Given this list of marker genes TMPRSS2, ACE2, M, S, E, N, 7a, SARS coronavirus, complete genome, 3a, VCP, CTSL, here is a description of the gene set: studied in species Homo sapiens Coronavirus replication is initiated by the binding of S protein to the cell surface receptor(s). The S protein is composed of two functional domains, S1 (bulb) which mediates receptor binding and S2 (stalk) which mediates membrane fusion. Specific interaction between S1 and the cognate receptor triggers a drastic conformational change in S2, leading to fusion between the virus envelope and the cellular membrane and release of the viral nucleocapsid into the host cell cytosol. Receptor binding is the major determinant of the host range and tissue tropism for a coronavirus. Some human coronaviruses (HCoVs ) have adopted cell surface enzymes as receptors, angiotensin converting enzyme 2 (ACE2) for SARS-CoV-1 and HCoV NL63. The receptor-bound S protein is activated by cleavage into S1 and S2, mediated by one of two of two host proteases, the endosomal cysteine protease cathepsin L and another trypsin like serine protease. Type II transmembrane serine proteases TMPRSS2 and TMPRSS11D have also been implicated in the activation of S protein of SARS-CoV-1. Host factors may play additional roles in viral entry (not annotated here). Valosin containing protein (VCP) contributes by a poorly understood mechanism to the release of coronavirus from early endosomes. Host factors may also restrict the attachment and entry of HCoV. Some interferon inducible transmembrane proteins (IFITMs) exhibited broad spectrum antiviral functions against various RNA viruses including SARS-CoV-1 while others may facilitate HCoV entry into host cells (Fung & Liu 2019). part of: SARS-CoV-1 Infection Reactome Pathway: Attachment and Entry_9678110